Given this list of marker genes Pax4, Sst, G6pc2 (NCBI Gene Id 14378), Ins2, Vdr, Insm1, Lmo2, Neurod1, Pax6, Spcs1 (NCBI Gene Id 69019), Pak3, Dcx, Foxa2, Syt13, Neurog3, Srp14, Pklr, Elp4, Nkx2-2, Stxbp1, Srprb, Gck, Slc2a2, Abcc8 (NCBI Gene Id 330527), Dpp4, Chga, Scgn (NCBI Gene Id 214189), Sec11a, Akt3, Hnf1a, Pcsk2, Gcg, Pcsk1, Iapp, Isl1, Pdx1 (NCBI Gene Id 18609), Mafb, Nkx6-1, Foxo1, here is a description of the gene set: studied in species Mus musculus from publication Howe DG, Blake JA, Bradford YM, Bult CJ, Calvi BR, Engel SR, Kadin JA, Kaufman TC, Kishore R, Laulederkind SJF, Lewis SE, Moxon SAT, Richardson JE, Smith C (PMID 30224793) Mouse genes annotated to HALLMARK_PANCREAS_BETA_CELLS based on orthology mappings provided by the Alliance Genome Consortium Mouse Gene Set: HALLMARK_PANCREAS_BETA_CELLS